The following is a description of a gene set: Human Gene Set: ATGTACA_MIR493 Genes having at least one occurence of the motif ATGTACA in their 3' untranslated region. The motif represents putative target (that is, seed match) of human mature miRNA hsa-miR-493 (v7.1 miRBase). species: Homo sapiens, and this is the list of marker genes: CDC14A, CLRN1, MED17, TNFSF11, AXIN1, SPAG8, KBTBD2, TBK1, USP6, BHLHE41 (NCBI Gene Id 79365), CARM1, KCNIP4, ZIC1, GABRA5, UNC5A, NLGN3 (NCBI Gene Id 54413), MTDH, ADGRL3, UBE2V2, CPNE8, CNOT6, SVIL, ACAP2, HS3ST3B1, RASAL2, ADCY1, OSBPL6, BMERB1, ABTB2, GTF2IRD1, KIF1B, CELF2 (CUGBP Elav-like family member 2), IRF2, PHF12, PIKFYVE, SRSF11, RIMS3, SAT1, TBC1D4, SPIRE2, ZFAND5 (zinc finger AN1-type containing 5), ARID1A, ZMYND19, MTPN, UBE2Q2, SIPA1L3, CSNK1A1, SORCS3, LRIG1, PPP2R5D, SOX21, ANO4, ERC2, ARFGEF1, FAT1, VGLL4, MLLT10, ZNF800 (NCBI Gene Id 168850), ATP2A2, SNRNP70, EYA1, BRD7, POU4F1, DAB2IP, LSM14A, PFN2, SRPK2, DLL1, CREBBP, ANTXR1, NMT1, GNB1, ZNF532, VAMP2, DNAJC13, INTS8, CDC73, ZIC2, BASP1, RBBP6, NUDT4, BCOR (BCL6 corepressor), SRSF3, PUM2, TBL1XR1, JPH1, DNAJC21, DACH1, SS18, GAD1, ZDHHC17, FOXO1, RNF38, BTG1, TMEFF1, HIPK1, PTPN12, RYBP, GAB1, EPHA7, ARHGAP5, PGRMC2, DCUN1D1, CHSY3, FNIP1, OVOL1, ENAH, WNT5A, MARK1, MAP1B, SERTAD2, RASL11B, NAB1, TM2D3, PDZRN3, MAPK1, GRM5, IRF7, TRIR, PPP1R10, UBE3A, AHDC1, SLC22A23, SEMA4C, IL1A, KLF3, GIT1, FAM120A, SDC2, PIAS1, MED26, ETF1, SH2D3C, XPO7, BCL2, DGKI, GOLM2, DHX36, AAR2, DOCK9, HEMGN, ANKRD17, PCDH19, SIPA1L2, KCNMA1, TMTC1, SEL1L, NCOA1, SNAI1, SMC6, TRPS1, SMG1, TAB3, NAV2, GSKIP, SRPX, AR, CDH13, PCDH18 (NCBI Gene Id 54510), SNX9 (NCBI Gene Id 51429), HIVEP2, EFNA3, ZMIZ1, MADD, MFSD6, FZD4, NBEA, KDM6A, FBXO33, VPS13D, UNC50, ATAD2, LRRTM3, MBD5, ARID1B, PHF20L1, CLASP1 (cytoplasmic linker associated protein 1), ZNF804A, AP3S1, LARP4, UBE2Q1, SPRYD3, ANKRD34B, CSNK1A1L, CHKB, ITGB1, FHOD3, ITSN2, SALL1, PRPF38B, HIC2, USP32, COBLL1, PDGFC, ARHGAP44, CITED2, ADAM10, KPNA4, NDST1, IRX3, SP4, NLGN1, FAM91A1, BAZ1B, AK5, GABRG2, RPE, E2F6 (E2F transcription factor 6), ZNF362 (zinc finger protein 362), USP21, FIGN, SP3, HMGCS1 (3-hydroxy-3-methylglutaryl-CoA synthase 1), TTC7B, RHOT1, NADK, PBX3, CLPX (NCBI Gene Id 10845), FMNL2, SSH2, TAOK3, NXPH1, TTN, PSD2, PDE4D, MAST1, MAML3, EIF4ENIF1, TMEM106B, TRAM2, SPRED2, TLE4, RSBN1, CAPN3, ANKRD50, RBM12, PHF2, DUSP16, AFF3, WDFY3, NCAPH, ZFC3H1, PPP3CB, BTAF1, SELENOS, KDM5B, GBF1, CCNT2, ATP5F1A, MED13L (NCBI Gene Id 23389), BRD10, TM9SF3, MEF2C, MED13, JUN, EFL1 (elongation factor like GTPase 1), PLPPR5, TNRC6B (trinucleotide repeat containing adaptor 6B, NCBI Gene Id 23112), RALGPS1, CTNND2, MBNL2, SH2B3, GPC4, PMP22, CTDSPL, ZNF711, PREX1, CUL5, PPP2R5C, TJP1, SPEN, PDPK1, PIK3R1, APLP2, BAZ2A (bromodomain adjacent to zinc finger domain 2A), REEP1, LPCAT1, PCGF2, DLG2, SLC25A26, CTNND1, ZFX, OTUB1, HERPUD2, PHAF1, PAIP1, ZBTB11, PPP2R2C, FBRS, CDH2, RPS6KA5, FAM76B, PDS5A, SYNE1, DIP2C, NRXN3, SV2B, HNRNPA0, ESRRG, LCA5, ANKRD28, PPTC7, ZNF706, DKK2, BCL7A, ZNF385B, AGO1, UBE2G1, FGF13, MCL1, GABRA1, SIN3A, CDH11, DDX3X, LRP12, BHLHE22